The following is a description of a gene set: species: Homo sapiens Human Gene Set: REACTOME_TRANSCRIPTION_COUPLED_NUCLEOTIDE_EXCISION_REPAIR_TC_NER Transcription-Coupled Nucleotide Excision Repair (TC-NER), and this is the list of marker genes: RPA2, POLE2, GTF2H3, ERCC5, ERCC3, POLR2L, COPS8, POLR2F, XRCC1, XPA, RFC2, POLD2, LIG3, POLK, MNAT1, CUL4B, COPS4, RFC3, COPS5, POLD1, ERCC8, ERCC2, GTF2H4, GTF2H5, ERCC1, ERCC6, RPA1, POLE4, ERCC4, UBA52, POLR2J, UBB, POLR2K (RNA polymerase II, I and III subunit K), COPS3, TCEA1, CUL4A, COPS7A, ELL (NCBI Gene Id 84205), COPS2, DDB1, RPS27A, XAB2, POLD4, GPS1, POLR2B, PPIE, COPS7B, PCNA, POLR2A, POLR2C, PRPF19, GTF2H2, POLR2G, POLR2E, RBX1, COPS6, UBC, CDK7, GTF2H1 (general transcription factor IIH subunit 1), UVSSA (NCBI Gene Id 57654), ZNF830 (NCBI Gene Id 91603), LIG1, RFC4, RFC1, CCNH, POLE3, POLR2I, POLR2H, RFC5, AQR, POLD3, ISY1, USP7, POLR2D, RPA3, POLE